Given this list of marker genes Gm1110, Gale, Glb1l, Glb1l3, Pgm1, Glb1l2, Galt, Galm, Glb1, Galk1, here is a description of the gene set: Mouse Gene Set: GOBP_GALACTOSE_CATABOLIC_PROCESS The chemical reactions and pathways resulting in the breakdown of galactose, the aldohexose galacto-hexose. species: Mus musculus